Given this list of marker genes DLX4, RIMS2, CXCL3, TENM2-AS1, IGF2, MYF6, KPNA4 (NCBI Gene Id 84857), HOXA1, YKT6, IPCEF1, HNRNPD, TMEM108, ZNF532, IFITM1, STKLD1, HMGCS2, here is a description of the gene set: Genes with some basal expression and partially methylated promoters, up-regulated by the combination of TSA and decitabine in RKO cells (colorectal cancer). species: Homo sapiens from publication Suzuki H, Gabrielson E, Chen W, Anbazhagan R, van Engeland M, Weijenberg MP, Herman JG, Baylin SB (PMID 11992124) Aberrant hypermethylation of gene promoters is a major mechanism associated with inactivation of tumor-suppressor genes in cancer. We previously showed this transcriptional silencing to be mediated by both methylation and histone deacetylase activity, with methylation being dominant. Here, we have used cDNA microarray analysis to screen for genes that are epigenetically silenced in human colorectal cancer. By screening over genes, we show that our approach can identify a substantial number of genes with promoter hypermethylation in a given cancer; these are distinct from genes with unmethylated promoters, for which increased expression is produced by histone deacetylase inhibition alone. Many of the hypermethylated genes we identified have high potential for roles in tumorigenesis by virtue of their predicted function and chromosome position. We also identified a group of genes that are preferentially hypermethylated in colorectal cancer and gastric cancer. One of these genes, SFRP1, belongs to a gene family; we show that hypermethylation of four genes in this family occurs very frequently in colorectal cancer, providing for (i) a unique potential mechanism for loss of tumor-suppressor gene function and (ii) construction of a molecular marker panel that could detect virtually all colorectal cancer. Human Gene Set: SUZUKI_RESPONSE_TO_TSA_AND_DECITABINE_1B